The following is a description of a gene set: Venous thrombosis Human Gene Set: HP_VENOUS_THROMBOSIS Formation of a blood clot (thrombus) inside a vein, causing the obstruction of blood flow. species: Homo sapiens, and this is the list of marker genes: CASR, SAA1, JAK2, ACVRL1, CD55, TRPV6, GDF2, EPAS1, HLA-DPB1, SERPIND1, AEBP1, CPA1, KLRC4, FGA, THBD, PRORP, CTRC, AKT1, PRTN3, HBB, PIGA, PIGM, F5, HABP2, TET2, IL12A, CALR, F13A1, SH2B3, PIEZO1, CCR1, F8, ENG, UBAC2 (UBA domain containing 2), CBS, MTRR, PRSS1, THPO, FGB, SLC4A1, MTHFR, PROC, PTPN22, SPINK1, PTH1R, STAT4, PMM2, HLA-DPA1, CFTR, MMACHC, FAS, NOTCH1 (notch receptor 1), KCNN4, IDH1, SMAD4, IL12A-AS1, IDH2, ACVR1, F2, TLR4, PROS1, PGM1, IL23R, IL10, PIK3CA, HLA-B, F9, ERAP1, MPL, GNAQ, KIF11, ALG6, SERPINC1, TGFB2, AGGF1, C4A, CTLA4, PRSS2 (NCBI Gene Id 93431), TP53, PDGFRA, IFNGR1, EPOR, FGG, MET (NCBI Gene Id 4233), MEFV, UBA1, CTNNB1